Given this list of marker genes Rnf7l, Ube2m, Rbx1, Rbx1-ps, Ube2f, Rnf7, Mdm2, Ube2frt, here is a description of the gene set: studied in species Mus musculus Mouse Gene Set: GOMF_NEDD8_TRANSFERASE_ACTIVITY Catalysis of the transfer of NEDD8 from one protein to another via the reaction X-NEDD8 + Y = Y-NEDD8 + X, where both X-NEDD8 and Y-NEDD8 are covalent linkages.